Given this list of marker genes Rnaset2a, Ccnd3, Vars1, Ly6e (lymphocyte antigen 6 family member E), Rnaset2b, Tsc22d3, Ly6a, Apobec3, Igfbp4, Snrpg, Dtx1, Socs3, Stat3, Pdcd4, here is a description of the gene set: Cytokines mediate cell-cell communication in the immune system and represent important therapeutic targets. A myriad of studies have highlighted their central role in immune function, yet we lack a global view of the cellular responses of each immune cell type to each cytokine. To address this gap, the authors created the Immune Dictionary, a compendium of single-cell transcriptomic profiles of more than 17 immune cell types in response to each of 86 cytokines (>1,400 cytokine-cell type combinations) in mouse lymph nodes in vivo. A cytokine-centric view of the dictionary revealed that most cytokines induce highly cell-type-specific responses. For example, the inflammatory cytokine interleukin-1β induces distinct gene programmes in almost every cell type. A cell-type-centric view of the dictionary identified more than 66 cytokine-driven cellular polarization states across immune cell types, including previously uncharacterized states such as an interleukin-18-induced polyfunctional natural killer cell state. Mouse Gene Set: CUI_T_CELL_CD8_OSM_RESPONSE_UP Genes positively differentially expressed in cell type: CD8+ T cell upon treatment with cytokine: OSM in mouse lymph nodes in vivo. from publication Cui A, Huang T, Li S, Ma A, Pérez JL, Sander C, Keskin DB, Wu CJ, Fraenkel E, Hacohen N (PMID 38057668) species: Mus musculus